Given this list of marker genes Mtmr4, Tph1, Sec16a, Coq5, Nudt4, Repin1, Ccdc97, Prkx (NCBI Gene Id 19108), Dock11, Cd99l2, Hic2, Timm29, Trabd2b, Ppef1, Mical2, Pou2af2, Rgp1, Eps15l1, Adhfe1, Cav2, Ssmem1, Snrk, Pygm, Ppp1r14d, Atxn1, Kcnc4, Ipo11, Fyco1, C5ar1, Rnasel, Add2, here is a description of the gene set: from publication Chen Y, Wang X (PMID 31504780) Genes predicted to be targets of miRBase v22 microRNA mmu_miR_23a_5p in miRDB v6.0 with MirTarget v4 prediction scores > 80 (high confidence targets). species: Mus musculus Mouse Gene Set: MIR_23A_5P